Given this list of marker genes CFAP410, CRYBB3, PANK4, EFEMP1, GNPAT, VIM, NR2E3, WFS1, CRYGB, CRYBA4, GALK1, NHS, GJA5, MVK, NF2, IMPG2, GNAQ, BFSP1, RECQL4, GJA8, CLPB, GNA11, SF3B1, FTL, SLC2A1, BEST1, OCRL, FZD5, MAF, PAK2, OPA3, CRYGC, COL18A1, RTN4IP1, SEC23A, LIM2, CRYBB1, KIAA1549, CHMP4B, GJA3, FYCO1, CRYGS, ZNF408, CRYBB2, ACADS, MIP, GJA1, BAP1, PRG4 (NCBI Gene Id 787), CRYBA1, HSF4, CYSLTR2, here is a description of the gene set: species: Homo sapiens Human Gene Set: HP_ZONULAR_CATARACT Zonular cataract Zonular cataracts are defined to be cataracts that affect specific regions of the lens.